Given this list of marker genes FGF2, FGFR1, LGMN, P2RX4, HSPB1, FGF18, MET, TMSB4X, SMOC2, PRKD2, VEGFA, FGF16 (fibroblast growth factor 16), KDR, PRKD1, SEMA5A, here is a description of the gene set: Human Gene Set: GOBP_POSITIVE_REGULATION_OF_ENDOTHELIAL_CELL_CHEMOTAXIS Any process that activates or increases the frequency, rate or extent of endothelial cell chemotaxis. species: Homo sapiens